Given this list of marker genes STAT5A, LEPR, GH2, JAK2, STAT5B, GH1, LEP, STAT3, PRLR, CSF3R, EPO, EPOR, CSF3, PRL, THPO, MPL, GHR, here is a description of the gene set: species: Homo sapiens Human Gene Set: KEGG_MEDICUS_REFERENCE_HORMONE_LIKE_CYTOKINE_TO_JAK_STAT_SIGNALING_PATHWAY Hormone-like-cytokine to Jak-STAT signaling pathway. Pathway ID: N01555. Pathway type: Reference. Pathway class: nt06518 JAK-STAT signaling. Pathway Definition from KEGG: (EPO,GH,PRL,THPO,CSF3,LEP) -> (EPOR,GHR,PRLR,MPL,CSF3R,LEPR) -> JAK2 -> (STAT5A,STAT5B,STAT3)